The following is a description of a gene set: species: Homo sapiens Binding to an interleukin-12 receptor. Human Gene Set: GOMF_INTERLEUKIN_12_RECEPTOR_BINDING, and this is the list of marker genes: IL23R, IL12B, JAK2, IL12A, IL12RB1